The following is a description of a gene set: In order to identify the molecular mechanisms of PPARgamma phosphorylation at Set273, we generated cell-lines of PPARgamma KO MEFs expressing wtPPARgamma or S273APPARgamma. In addition, because our data showed that PPARgamma ligand drugs such as rosiglitazone and MRL24 blocked this phopshorylation, we treated cells with these drugs, then prepared RNA samples to look at the gene profiling. studied in species Homo sapiens from publication Choi JH, Banks AS, Estall JL, Kajimura S, Boström P, Laznik D, Ruas JL, Chalmers MJ, Kamenecka TM, Blüher M, Griffin PR, Spiegelman BM (PMID 20651683) Human Gene Set: GSE22033_UNTREATED_VS_ROSIGLITAZONE_TREATED_MEF_UP Genes up-regulated in mouse embryonic fibroblasts (MEF): untreated versus rosiglitazone., and this is the list of marker genes: SEC22A, DCP2, DUS4L, CEBPA, ARHGAP33, HNRNPM, MPHOSPH10 (NCBI Gene Id 10199), CKS2, RPS6KB1, HSPA1L, PSMG2 (NCBI Gene Id 56984), OR1D2, NHEJ1, RNF31, LPIN2, TMED2, SSR1, FN3KRP, RBM26, SACM1L, PELP1, HDHD5, RAB11A (RAB11A, member RAS oncogene family), INTS5, BLVRA, COPS7B, KIF1C, MTERF1, VIPAS39, TUBBP5, TSR3, UBA3, GDE1, TARS2, COX7A2, KLHL35, NFE2L3, NACA, RNF7, VDAC1, SLC13A3, RBFA, HS1BP3, PEX1, ENTPD3, DDX49, ERP29, SLC27A5, ZNF415, HARS2, MRTFB, RNF146, STAM, CLCN7, PGRMC2, ELOB, LARS1, MTNAP1 (mitochondrial nucleoid associated protein 1), ATP5MC2, DTYMK, CYP2E1 (cytochrome P450 family 2 subfamily E member 1), ORC4, INPP5B, RRM1, PCYOX1L, LMO2, FAM200C, NEIL3, DOK3, CARD9, YLPM1, ARG2, HPS4, SET, TJP2, GTF3A, SNRPN, SH3PXD2A, TBCA, LAS1L, TMEM63A, COA7, UNC119B, LSM4, RAB5IF, DIO2, ZNF175, ARHGEF3, SLC35A1, COQ4, TFR2, DSTYK, FAN1, TCEAL9, PRPF19, TMEM80, VDAC3 (voltage dependent anion channel 3), CEP76, CD72, AP5S1, SNRPG, ESD, MCM3, SMIM7, RNF4, PRCC, PDK2, CLPB, IL10RB, SUPT20H, CMAS, NFKBIE, TUBA4A, CENPJ, HOXB13, PDCD5, DTWD1, CSRP1, BCKDHA, TK1, ADCY7 (adenylate cyclase 7), ZNF74, SMG9, SLC66A2, APEX2, HTRA2, PACSIN2, LAX1, STN1, ALDH18A1, PLIN3, OLA1, CREBZF, ZMYM6, MGMT, MAPK12, CASKIN2, TIMM17A, ZKSCAN3, ARFIP1, ZBTB3, NOL12, SIGMAR1, GIMAP5, UBB, PIK3C2B (NCBI Gene Id 5287), SCAMP1, ASH2L, PHF20, RPL26L1, C6orf47, ADK (adenosine kinase), NUP37, CLPP, CAD, CORO1A, TRAPPC12, ANAPC13, TOMM34, MOB4, ERMAP (erythroblast membrane associated protein (Scianna blood group)), PRIM1, MRPL46, TRAF2 (NCBI Gene Id 7186), NEK9, ACTL6A, FAM162A, ALG6, ZCCHC4, FAM89B, CNOT8 (CCR4-NOT transcription complex subunit 8), LSM1, GIT2, TMEM109, BMAL1, TP53, DDX54, MPST, CCNB2, CBX5, PPM1D, CEP68, EFCAB11, NDUFA8, C3AR1, DPM3, RUVBL2, ASB1, FHL1, GOT2, HNRNPF, NHP2, MRFAP1L1 (NCBI Gene Id 114932), XPA, NSFL1C, RPL18, KRAS, MICALL1, TIMELESS, TNRC6B